The following is a description of a gene set: The process in which the 5' end of a pre-tRNA molecule is converted to that of a mature tRNA. species: Mus musculus Mouse Gene Set: GOBP_TRNA_5_END_PROCESSING, and this is the list of marker genes: Rpp21, Rpp38, Rpp40, Rpp14, Pop1, Pop7, Prorp, Rpp25l, Hsd17b10, Rpp30, Pop4, Rpp25, Ssb, Trmt10c, Thg1l, Pop5